The following is a description of a gene set: Hematemesis Human Gene Set: HP_HEMATEMESIS The vomiting of blood. studied in species Homo sapiens, and this is the list of marker genes: ACVRL1, PKHD1, GP1BA, CDKN1B, CDKN2C, MED12, ENG, CDKN1A, CDKN2B, ATRX, FGA, FGG, FGB, IFIH1, GP1BB, WAS, WIPF1, MEN1, GP9, F8, F9